Given this list of marker genes Irf3, Ly96, Ticam2, Optn (optineurin), Rps27a, Irf7, Cd14, Traf3, Tlr4, Ubb, here is a description of the gene set: electronically inferred by orthology from the curated human pathway part of: TRIF (TICAM1)-mediated TLR4 signaling  Reactome Pathway: Activation of IRF3, IRF7 mediated by TBK1, IKKε (IKBKE) species: Mus musculus This event has been computationally inferred from an event that has been demonstrated in another species.<p>The inference is based on the homology mapping from PANTHER. Briefly, reactions for which all involved PhysicalEntities (in input, output and catalyst) have a mapped orthologue/paralogue (for complexes at least 75% of components must have a mapping) are inferred to the other species.